The following is a description of a gene set: Androgen receptor network in prostate cancer studied in species Homo sapiens Human Gene Set: WP_ANDROGEN_RECEPTOR_NETWORK_IN_PROSTATE_CANCER, and this is the list of marker genes: STAT3, GRB2, BRCA1 (BRCA1 DNA repair associated), TP53, CDK4, CDKN1A, SMARCC1, MIR21, CDKN1B, CASP9, RPTOR, PXN, ERG, SMARCD3, CDK1, MYC, CRK, MTOR, FOS, MDM2, RASA1, MAPK1, HSD17B4, ETV4, JUN, PLK1, CYP17A1, SPRY1, SPINK1, ARID1B, BCL2, PRKDC, CRKL, HGF, CHEK1, SMARCC2, CASP8, JAK1, KLK2, SMAD3, MRE11, EIF4EBP1, GAB1, BAX, CASP3, CCND1 (NCBI Gene Id 893), FKBP5, HSD3B1, PIK3CA, E2F1, ATR, MAPK8, CHEK2, CDKN2B, KLK3, CDC25A, SP1, HSD17B3, HRAS, MSH6, HSD3B2, AKT1, HSD17B7, MAPK3, F13B, ACTL6A, SOS1, ATF1, SMAD2, MAP2K1, DOCK1, MAPK14, ARID1A, ATM, PTK2B, SPRY2 (sprouty RTK signaling antagonist 2), RAD50, SMARCD2, EIF4E1B, FOXA1, CPN1, NOXA1, RB1, BARD1, SMARCD1, MAP2K2, STAT1, PTEN, ACTL6B, RAP1A, BAD, HSD17B2, ABCC4, RICTOR, RAF1, NDRG1, CDC25B, CDK2, AR, TSC2, PAK1 (p21 (RAC1) activated kinase 1), MMP1, SMARCA4, MAP4K1, MSH2, RAPGEF1, RHEB, HSD17B1, ELK1, RAP1B, PTPN11, BLM, TSC1, CDKN2A